Given this list of marker genes COL9A1, COL11A2, COL2A1, ERBB3, COL11A1, here is a description of the gene set: Human Gene Set: HP_DEGENERATIVE_VITREORETINOPATHY species: Homo sapiens Degenerative vitreoretinopathy